Given this list of marker genes ERCC8, ERCC6, POLD4, ISY1, POLR2J, CUL4B (NCBI Gene Id 8450), UBB, ZNF830, LIG1, DDB1, RPA1, POLR2K, XAB2, POLR2H, CDK7, ERCC2, AQR, RFC2, RFC4, USP7, ERCC3, XRCC1, GTF2H4, POLR2F, POLR2B, RPA3, UBA52, POLD1, GTF2H5, GTF2H2, MNAT1, POLK, RPS27A, POLR2A (NCBI Gene Id 5430), POLD3, POLE2, PCNA, POLE3, PPIE, POLR2L, CCNH, RFC1, UBC, POLR2D, RBX1, LIG3, POLR2G, POLE4, GTF2H1, GTF2H3, POLR2C, PRPF19, POLD2 (DNA polymerase delta 2, accessory subunit), UVSSA, CUL4A, RFC5, RPA2 (NCBI Gene Id 6118), POLR2E, POLR2I, POLE, RFC3, TCEA1, here is a description of the gene set: In transcription-coupled nucleotide excision repair (TC-NER), similar to global genome nucleotide excision repair (GG-NER), DNA polymerases delta or epsilon, or the Y family DNA polymerase kappa, fill in the single stranded gap that remains after dual incision. DNA ligases LIG1 or LIG3, subsequently seal the single stranded nick by ligating the 3' end of the newly synthesized patch with the 5' end of incised DNA. part of: Transcription-Coupled Nucleotide Excision Repair (TC-NER) studied in species Homo sapiens Reactome Pathway: Gap-filling DNA repair synthesis and ligation in TC-NER